Given this list of marker genes ROBO2, PTPN13, TLR2, SLIT1, CLSTN3 (NCBI Gene Id 9746), DKK1, WNT5A, CBLN1, EPHA7, here is a description of the gene set: Human Gene Set: GOBP_NEGATIVE_REGULATION_OF_SYNAPSE_ASSEMBLY Any process that stops, prevents, or reduces the frequency, rate or extent of synapse assembly, the aggregation, arrangement and bonding together of a set of components to form a synapse. studied in species Homo sapiens